Given this list of marker genes METTL21A, PDCL3, DNAJB2, DNAJB1, PDCD5, here is a description of the gene set: Any process that modulates the frequency, rate or extent of chaperone-mediated protein folding. species: Homo sapiens Human Gene Set: GOBP_REGULATION_OF_CHAPERONE_MEDIATED_PROTEIN_FOLDING